Given this list of marker genes UBQLN4, HTR5A, GOLGA5, AKNA, SIK3, PPAN-P2RY11, TDP1, LINC01275, MBTPS1, RNA5SP473, DNALI1, ENSG00000253986, KLHL23, RNU5E-1, DYNLT4, ADAT2, P2RX6P, EFHB, IK, LINC00630, CHRNA7, TMED10, ALG1L13P, TUFT1, MRPS21, DRC7, LINC02288, IRF2BPL, TMEM67, IFT56, CATIP, HMGB1P33, LINC00970, ASTE1, DNAH7, EFHD2-AS1, GSE1, SLC25A14, NDUFAF4P1, FGR, RFX2, PRR3, HNRNPUL1, PER1, ZNF585A, SLC22A11, MIR4290HG, RN7SL632P, STXBP5-AS1 (STXBP5 antisense RNA 1), PEX3, GDF15, KLHL24, CCDC91, SUN2, CIMAP1C, RMND5A (required for meiotic nuclear division 5 homolog A), MPC2, LAMTOR2, VTRNA1-2, KLF2, WDPCP, FPGT-TNNI3K, EFHD2, MINDY1, RRM2B, WDR46, MAFK, NOD2, EMC3, IGHV3-35, ALDH1A2, ING3, CPN2, MYL3, TTLL5, MED31, ECT2, GTF2IRD1P1, CNIH2, ZNF585B, SFR1, DCAF6, RNA5SP60, RASSF4, RBM45, DYNLT1, DSTYK, MBTPS1-DT, PDK4-AS1, GIHCG, EFCAB11, FOSB, BSG, CFAP58-DT, SPA17, ETFRF1, SIAE, LACTB2-AS1, PCSK6, RNU6-218P, CRIP2, CIC, ZSWIM8, PRUNE1, MIR7-3, PIM1, MAP4K3 (NCBI Gene Id 8491), RGL2, PPP2R3C, NAA20, DHX40, RN7SL813P, CFAP126, MAST3-AS1, DHX8, LRRC74B, YIPF4, MIER1, NRP2-AS1, NKAPP1, RBM23, OTOS, ZNF474 (zinc finger protein 474), CABIN1 (NCBI Gene Id 26293), SMC1A, SETD5, ENSG00000232995, MIR3189, ARRDC3-AS1, SUN1, EFHC1, ZBTB20-AS5, KLF4, MAML3, ASMER1, LINC02734, CDK12, TFAP4, HBP1, PRORP, CFAP298-TCP10L, THBS3, ZNF487, PPP1R15B, CSF1, CFAP96, RARA, CC2D2A, VPS26BP1, GET3, ZC3H10, CNNM3, FOXJ1, IFRD2, SLEAR, SMPD2, NUDT13, ZNF497, TIMM17B, CBLL1, DNAI7, NPIPB2, FGGY, ERLEC1, PLEKHF2, TGIF1, TMEM212, NFE2, ACYP1, TSPYL1, LRRC27, IL5RA, STAP2, TIMM44 (translocase of inner mitochondrial membrane 44), SRFBP1, CCDC174, RGS5, TARS1-DT, CFAP276, RERE, HIBADH (3-hydroxyisobutyrate dehydrogenase), PANK4, H4C8, FAM81B, ARHGAP4, ZDHHC1, TBC1D16 (TBC1 domain family member 16), NUP62CL, MLLT1, TREX1, ASB7, FBXO32, LINC01220, LINC02265, ATP6V0D2, ZNF350, ZNF131, AP2S1, ZBBX, TCEANC, EFHC2, GAL3ST4, TCEA2, ARMC3, MVB12A, ZNF324 (NCBI Gene Id 64287), STK32C, ENY2, ILF3-DT, ZFR, MLXIPL, MTX1, DNAL4, CLMP, CCDC157, CRPPA-AS1, FHL1, CLGN, NUBPL, NSDHL, LINC02577, ZSCAN18, NOP14, BCO2, STAT6, RFX1, CFAP298, PIK3R2 (phosphoinositide-3-kinase regulatory subunit 2), SELENOKP1, HIPK1, NUF2 (NCBI Gene Id 83540), GET1, CCDC191, OPA1, DYRK1B, CENPBD2P, NBAS, RNF157-AS1, KIF27, GGPS1 (NCBI Gene Id 9453), PIK3CA, WBP1, STRIP1, DNAJC16, GOLGB1, CLPB, ERCC1, LINC02369, KLHL18, PTCH1 (patched 1), GRK4, UBL7-DT, BMAL1, AQP10, TPPP3, FAM227B, MBTPS2, SAMSN1-AS1 (NCBI Gene Id 100874190), PFDN6, BRMS1, CFDP1, LRGUK, MOK, LMNA (lamin A/C), NLK, ESYT1, STAG2, KRT8, MRPS14, KNCN, CDKL1, IDS, TAGLN2, TOR2A, FOXO6, CCDC40, LCORL, RPRD1B, DUS3L, ZNF37BP, PSMA3-AS1, CFAP69, ZNF837, EFCAB2, MED25, GABARAPL1, JMJD1C, SPINK4, MIR4259, ST18, TMEM139, CYTH2, NSFL1C, FMR1-AS1, CASP9, BSG-AS1, NRP2, CDH23, MRPL24, PMFBP1, ST7, RPL36AP19, ISYNA1, TBL1X, FMR1, RPS6KA5, SPAG1, ZDHHC14, DAZAP1, DTWD1, HMBOX1, ASB3, LINC01126, L3MBTL2, VRK3, RSPH4A, CITED2, PQBP1, LRRC71 (NCBI Gene Id 149499), ERICH6, SLC16A1, PIBF1, CBX5, ENSG00000235066, NUPR1, DYRK2, FUZ, ADGRG1, ZNF473, CRISP1, TXNIP, DDX49, LRRC23, SELENOP, RNU6-107P, LINS1, DYRK3, ZCWPW2, ANKRD42-DT, TTC41P, LINC02418, TENT5C, MDH1, AKT1S1, CRTC2, UBXN11, DDX3X, ARHGAP25, NR4A2, PHB1P1, PPP1R15A, TBC1D17, DYRK1A, SLC6A12, WHRN, PCGF5, UBL7, ENSG00000269091, ZSCAN31, RPL17P41, SPNS1, RRP12, PCSK6-AS1, TCP11L2, RFX3-DT, ACTR3C, CFAP210, MBD4, MAPRE3, INTS9, SRSF7, YBX3, TFAM, LINC01876, PPAN, XPC-AS1, ALDOA, DYNC1I2, UBE2O, FPGT, CFAP141, RPGR (NCBI Gene Id 6110), MIR132, ZNF440, BABAM1, TTC7B-AS1, CLCN3, PIGL, MLF1-DT, FAAP20, SARAF, ZFYVE28, SNX29, PCAT6, RFC5, ETV1, HM13, EPHB6, USP49, ADTRP, SLC44A1 (solute carrier family 44 member 1), IQGAP2 (IQ motif containing GTPase activating protein 2), STAU2, NUDCD1, CIMAP3, KIZ, ARID4B, OTUD5, PIP4P1, IFT122, CENPF (centromere protein F), PPP1R12C, HSP90B1, CFAP107, UFSP2, C2CD2L, TMEM115, CREBL2, UBXN10, KPNA6, TACO1, ZC2HC1C, TENT5C-DT, CFAP54, LRRIQ3, ILF3, MAK, UPRT, INTS1, CMTM6, DIS3, PPOX, TRAM1, ENSG00000267732, JUND, PRMT5-AS1, CBX8, MPND, MBOAT4, CIMIP6, UBE2Z, C5AR1, SPAG8, ERICH6-AS1, CETN2, IFT20, PPIL6, WBP2, TXNDC11, FAM76A, QTRT2, NUBPL-DT, OSR2, CTU1, IPO13, HECTD1, TAPBP, NEK11, LINC01539, SLC38A2, ZFP36L2, PRKN, CFAP43, LINC01610, NDRG4, LYPLA2, NRM, PHOSPHO2, CFAP45, ARMC2, ZNF510, ZNF475, WEE2-AS1, GART, PES1, MIR3188 (microRNA 3188), PPP1R3E, NFIA, CFAP99, DNAI3, DNAAF6, SUMO3, C17orf100, LEMD2, LINC02532, SYNE2, FAM227A, RPS17P7 (NCBI Gene Id 100271069), UACA, YWHAE, TOM1L2, KIF9, SF3A1, THADA, P4HB, NCOR2, PBX1-AS1, MFSD4B, MKRN3, COPS2, EVI5, CREB5, FAM8A1, STRA6, EEF1A1P23, RFX3, DDX23, CAMK2D, MFSD4B-DT (NCBI Gene Id 107986521), YTHDC1, MNS1, WDR77, HNRNPF, FAM229B, MARCHF8, KAZN, ZFP36L1, MIR7-3HG, RSRC1, PACRG, SSBP1, NKAP, SDHC, ARMH4 (armadillo like helical domain containing 4), FEM1A, BDP1, CFAP58, ATXN7L3B, DSE, PDE4C, ARID4A, AACS, TUBE1, TOR1A, NFATC2, PIK3CA-DT, MYADM, AZI2, CIMIP5, TNFAIP1, EIF2D, ATP13A4, GNAS, HSF1, ZNF3, MLF1, KLF2-DT, GALK2, LINC02863, COPE, TIPARP, OAZ2, RIBC1, RABGAP1L (NCBI Gene Id 9910), ZNF511, ZNF584, ERG28, CENPH, DRC3, MIR4766, VTA1, USP2, ZMYND10, GNL1, DUSP16, YLPM1 (YLP motif containing 1), CHST11, TARS1, FAM13A, YJU2, PRECSIT, GEMIN6, CYB5R4, PHKG1 (phosphorylase kinase catalytic subunit gamma 1), C19orf44 (NCBI Gene Id 84167), PHF8, IQCG, ARL4A, EHD1, KLF13, CALR3, ARRDC3, SNHG27, ELAPOR1, KCNRG, DUSP10, ZNF165, NDUFA2, TLCD3B, ZNF395, ARG2, ANKRD42, KCND2, NCOA5, RPL35A, SIRT1, FAM185A, SF3B5, LUCAT1, DNAI4, TUBB4B, MZF1, USP2-AS1, CBY1, SNRPE, TEKT1, PSTPIP2, here is a description of the gene set: Human Gene Set: FOXJ2_TARGET_GENES Genes containing one or more binding sites for (FOXJ2) in their promoter regions (TSS -1000,+100 bp) as identified by GTRD version 20.06 ChIP-seq harmonization. studied in species Homo sapiens from publication Yevshin I, Sharipov R, Kolmykov S, Kondrakhin Y, Kolpakov F (PMID 30445619)